The following is a description of a gene set: The chemical reactions and pathways resulting in the breakdown of L-tryptophan into other compounds, including kynurenine. Mouse Gene Set: GOBP_L_TRYPTOPHAN_CATABOLIC_PROCESS_TO_KYNURENINE studied in species Mus musculus, and this is the list of marker genes: Kynu, Afmid (arylformamidase), Ido1 (NCBI Gene Id 15930), Ido2, Tdo2